Given this list of marker genes Chrm5, Chrm1 (NCBI Gene Id 12669), Chrm3, Chrm2, Chrm4, here is a description of the gene set: studied in species Mus musculus Combining with acetylcholine and transmitting the signal across the membrane by activating an associated G-protein; promotes the exchange of GDP for GTP on the alpha subunit of a heterotrimeric G-protein complex. Mouse Gene Set: GOMF_G_PROTEIN_COUPLED_ACETYLCHOLINE_RECEPTOR_ACTIVITY